Given this list of marker genes Acsl3, Atp2c1, Lyplal1, Rack1, Pkdcc, Cln3, Lypla1, Cnst, Csk, Vamp4, here is a description of the gene set: Any process that modulates the frequency, rate or extent of the transport of proteins from the Golgi to the plasma membrane. Mouse Gene Set: GOBP_REGULATION_OF_GOLGI_TO_PLASMA_MEMBRANE_PROTEIN_TRANSPORT studied in species Mus musculus